Given this list of marker genes Atp2b3, Gng8, Adcy5, Gjb4, Ywhaz, Rgs3, Prkcg, Rgs1, Casq2, Camk4, Adrb2, Gja8, Chrm5, Gnai3, Rgs9, Pkig, Prkar2b, Casq1, Prkar2a, Prkca, Gngt1, Chrm4, Rgs14, Prkch, Rgs5, Pkia, Gng5, Chrm2, Arrb2, Chrm1, Gjb6, Ywhag, Gng2, Prkcb, Gja5, Gnai1, Gjb1, Prkacb, Gng13, Prkce, Adrb3, Fkbp1a, Rgs4, Adra1b, Cacna1b, Atp2b1, Gng4, Gng7, Prkcz, Cacna1a, Ryr2, Gng12, Pln, Gng11 (guanine nucleotide binding protein (G protein), gamma 11), Gnb3, Adcy6, Kcnb1, Camk2a, Kcnj3, Ywhab, Gja3, Atp1b2, Ryr1, Cacnb3, Cacna1c, Adra1d, Gja4, Cacnb1, Prkd1, Gjc1 (NCBI Gene Id 353069), Gna11, Cacna1s, Itpr2, Rgs16, Calr, Ryr3 (ryanodine receptor 3), Gnao1, Prkcd, Atp1a4, Cacna1e, Rgs7, Gnaz, Slc8a1 (NCBI Gene Id 319418), Gjb2, Gnai2 (G protein subunit alpha i2), Prkcq, Fxyd2, Itpr1 (NCBI Gene Id 18544), Rgs10, Anxa6, Atp1b1, Atp2a2, Gnas, Atp1b3, Camk2g, Adcy8, Ywhae, Camk2b, Prkar1b, Camk1, Cacna1d, Atp2b2, Rgs17, Camk2d, Gjb5, Adrb1, Slc8a3, Grk5, Ywhah, Gnaq, Plcb3, Rgs18, Ywhaq, Itpr3, Adcy3, Chrm3, Sfn, Gjc2, Adcy9, Adcy1, Rgs6, Adcy4, Gng3, Grk4, Pkib, Adcy2, Gja1, Kcnj5, Adcy7, Grk6, Adra1a, Rgs2, Gnb4, Gjd2, Rgs19, Rgs20, Arrb1, Prkar1a, Rgs11, Gnb1, Gnb5, Calm3, Atp2a3, Gjb3, here is a description of the gene set: Calcium regulation in cardiac cells studied in species Mus musculus Mouse Gene Set: WP_CALCIUM_REGULATION_IN_CARDIAC_CELLS